Given this list of marker genes Jund, Pdk3, Lmo3, Bmp2, Asxl2, Ppara, Pparg, Aloxe3, Stub1, Fabp5, Twist1, Med1, Actn4, Cyp2j6, Rxra, Hmga1 (high mobility group AT-hook 1), Gps2, Cited2, Huwe1, Sirt1, Ncoa2, Ncoa1, Paqr3, Ptgis, Stard10, Lep, Alox15, Alox8, Plin5, Asxl1, Fam120b, here is a description of the gene set: Mouse Gene Set: GOBP_PEROXISOME_PROLIFERATOR_ACTIVATED_RECEPTOR_SIGNALING_PATHWAY species: Mus musculus A nuclear receptor-mediated signaling pathway initiated by a ligand binding to an intracellular peroxisome proliferator activated receptor (alpha, beta or gamma) of the nuclear receptor protein family, and ending with regulation of a downstream cellular process, e.g. transcription.